The following is a description of a gene set: species: Homo sapiens Human Gene Set: MODULE_68 Genes in the cancer module 68., and this is the list of marker genes: KRT5, KRT32, KRT8, DSP (NCBI Gene Id 202512), KRT18, KRT85, DRD2, KRT19 (NCBI Gene Id 3880), KRT4, KRT16, NEFL, KRT17, KRT1, INA, SPRR1B, KRT14 (keratin 14), KRT13, KRT35, KRT15, KRT33B, KRT6A, KRT86, KRT7, KRT6B, KRT2, VIM